Given this list of marker genes HDHD5, GPR18, RIPOR2, ACSF2, SUMF1, LLPH, NEDD4L, SASH3, SYDE1, PAK1, TNFAIP8L1 (NCBI Gene Id 126282), TANGO6, PYCARD (PYD and CARD domain containing), PIGV, CC2D2B, USP40, PRKAG2, MCOLN3, SAMHD1, ANAPC11, UCK1, DAPK1, TLR7, ARID3B, CLCF1, MKS1, CTSW, MLLT3, FAM78A, ARL5C, ARHGAP27, CLUAP1, PTP4A3 (NCBI Gene Id 11156), TUBGCP4, CTSS, PRPSAP2, SGK3, CEP68, TMSB10, CHCHD10, MYB, CAMSAP2, IKBKB, TREML2, FBXO7, RGS10, PGAM2, SF3A3, DZIP1, PRF1, GBP6, CRIPT, ID3, PARD6G, TRAPPC2L, KLF13, SLC46A3, CARD6, NUDT14 (nudix hydrolase 14), KAT2B, SSBP1, DNAJC19, STX1A, KRBA1, HASPIN, ATP6V0A1, EPHX1, PPM1M, RDH5, GABRR2, BOLL, METTL22, RREB1, USP24, ABLIM1, ADD3, PPP1R13B, TCTA (T cell leukemia translocation altered), PISD, AIP, NCF1, NDUFA6 (NCBI Gene Id 4700), JAK1, PDLIM5, FUBP1, CDIPT, BCAS2, EYA3, FBXL9P, MOV10, LDHD, ZBTB17, ADPGK, SLC49A4, MDP1, ZXDC, ZFC3H1, TBX6, AIRN, ARHGEF1, PPP1R9A, CCND3, PLCB2, SMG1, DAP3, RASGRP2, LEF1, PMS2, TRIB2, GRHPR, SLC26A11, USP18, RASSF2 (NCBI Gene Id 9770), GPR146, INO80, RAB5C, AOC2, TRMT1, RASA3, KCNIP2, FOXO1, CD247, MPP1 (NCBI Gene Id 4354), MLLT11, ATRNL1, STAMBPL1, SFXN3, IFT25, PIK3IP1, CD3D, SPSB1, SSH2, PPARGC1B, LSM4, ARMC7, S1PR1, LAT, PVR (PVR cell adhesion molecule), CD27, EVL, SCARNA17, DAPL1, SNAPC5, TMEM177 (NCBI Gene Id 80775), TRAF6, PARP11, SSU72 (NCBI Gene Id 79588), LGMN, KCNH2, RBM38 (NCBI Gene Id 55544), PIP4K2A, NPC1, ITGA6, GATB, ARF5, OPLAH, FAM53A, GBP5, CSTF1, NDRG3, MCUR1, DAXX, CHMP2A, RWDD4, NDUFA3, CDK19, RBCK1, TSPYL2, here is a description of the gene set: species: Homo sapiens Genes up-regulated in multipotent progenitors versus common lymphoid progenitors. from publication Ramirez K, Chandler KJ, Spaulding C, Zandi S, Sigvardsson M, Graves BJ, Kee BL (PMID 22608498) Human Gene Set: GSE37301_MULTIPOTENT_PROGENITOR_VS_COMMON_LYMPHOID_PROGENITOR_UP Expression profiling of Rag2-deficient Ets1++ and Rag2-deficient Ets1-- mature NK cells and WT bone marrow progenitors, WT T cells, and WT Pro B cells